The following is a description of a gene set: Human Gene Set: REACTOME_SIGNALING_BY_TYPE_1_INSULIN_LIKE_GROWTH_FACTOR_1_RECEPTOR_IGF1R species: Homo sapiens Signaling by Type 1 Insulin-like Growth Factor 1 Receptor (IGF1R), and this is the list of marker genes: CILP, AKT2, IGF1R, FGF2, PDE3B, PIK3CB, FGFR1, FGF8, FGF20, IRS4, PIK3R4, FGF10, KL, THEM4, KLB, FGF1, FLT3, FGF3, FGF18, FGF23, NRAS, GAB1, PIK3CA, PIK3R1, HRAS, FGF16, FRS2, PDPK1, FGF4, KRAS, FGF6, IRS1, IGF1, FGF7, FGF17, GRB2, FGFR3, PIK3C3, FGF19 (NCBI Gene Id 9965), IRS2, FGFR4, IGF2, FGF22, PIK3R2, FLT3LG, TRIB3, SOS1, FGFR2, SHC1, PTPN11, FGF9, TLR9 (toll like receptor 9), GAB2, FGF5